Given this list of marker genes Rigi, Isl1, Rasgrp1, Cd84, Il17d, Il18 (interleukin 18), Gja8, Il12b, Fcer1a, Fosl2, Slamf9, Tlr9, Syk, Il1b, Il23a, Il17f, Card9, here is a description of the gene set: species: Mus musculus Mouse Gene Set: GOBP_GRANULOCYTE_MACROPHAGE_COLONY_STIMULATING_FACTOR_PRODUCTION The appearance of granulocyte macrophage colony-stimulating factor due to biosynthesis or secretion following a cellular stimulus, resulting in an increase in its intracellular or extracellular levels.